The following is a description of a gene set: Mouse Gene Set: chr6E1 species: Mus musculus, and this is the list of marker genes: Gm6064, Gm19177, Cntn6, Gm23339, Gm44040, Gm18100, Gm4602, Gm25656, Sumf1, Gm34933, Trnt1, Gm24784, Gm5315, 4933431M02Rik, Chl1, Gm16433, Setmar, Lrrn1, Gm19757, Gm15631, Itpr1, Cntn4, Mir7661, Gm7946, Il5ra, Rpl36-ps12, Crbn, Pou5f1-rs5